Given this list of marker genes NOMO3, DACT1, CSNK2B, DACT2, ZC3H3, ACVR2A, FGF9, ACVR1B, SHH, SKI, ACVR2B, MAGI2, DMRT1, NOMO1 (NCBI Gene Id 23420), SMURF1, FGF10, NCLN, FKBP1C, CER1, IGSF1, FST, DAND5, SMAD6, SMAD7, LEMD3, FKBP1A, ACVR1, FSTL3 (NCBI Gene Id 10272), here is a description of the gene set: Human Gene Set: GOBP_REGULATION_OF_ACTIVIN_RECEPTOR_SIGNALING_PATHWAY Any process that modulates the frequency, rate or extent of the activity of any activin receptor signaling pathway. species: Homo sapiens